The following is a description of a gene set: Mouse Gene Set: REACTOME_INTERFERON_GAMMA_SIGNALING studied in species Mus musculus Interferon gamma signaling, and this is the list of marker genes: Ptpn2, Socs3, Prkcd, Sumo1, Raf1 (NCBI Gene Id 76876, v-raf-leukemia viral oncogene 1), Pias1, Camk2a, Ybx1, Camk2b, Ifngr1, Jak2, Ptpn6, Camk2g, Camk2d, Mapk1, Mapk3, Ifng, Socs1, Ifngr2